Given this list of marker genes Cox11, Ifit3b, Mterf1a, Fam174a, Supt5, Dhdds, Csnk1g1, Washc4, Cyb5d1, Adsl, Nucb1, Srebf1, Zfp60, Zfp384 (NCBI Gene Id 269800), Prorp, Lsm10, Hspb6, Cplane2, Tbc1d10b, Snord13, Rny1, Nat10, B130034C11Rik, Pigu, Cdk5, Gm23596, Tnfaip1, Gm11527, Smpd3, Gtf2b, Uggt2, Neil1, Unk, Xpo6, Prkar1a, Wdr75, Mrpl48, Mrps10, Tor2a, Ddx23, Nbr1, Nrdc, Sp140l2, Dpagt1, 4833445I07Rik, Zfp148, Mphosph10, Atp6v0b, Sfi1, Slc30a5, Syt3, Tox4, Car11, Cyb561a3, Mrps9, mt-Tm, Uckl1os, Iscu, Samsn1, Ndc1, Prdm2, 1110038B12Rik, Zfyve19, Rgs12, Cep89 (NCBI Gene Id 72140), H2ac18, Farsb, Sympk, Setmar, H2-M3, Snrpd3, Gabpa, Ugt1a1, B2m, Hypk, Lamtor1, Ppp1r12c, Atpsckmt, Taf7, Commd9, Rab29, Med20, Zfp759, Pnrc2, Uqcr10, Yars1, Lcorl, Rad17, Atf6b (NCBI Gene Id 54136), Aptx, Mfap1b, Rexo2, Dhodh, Bub1b, Dhfr, Cep76, Trmt1, Wdfy1, Snord1c, Vipas39, Cyb561d2, Rpain, Alpi, Rad51, Snx17, Wdr83, Klhl28, Ubr2, Max, Espl1, Cactin (cactin, spliceosome C complex subunit), Prpf19, Cilk1, Mzf1, Hsp90b1, Dnase1l3, Zfp128, Aurka, Vcpip1, Sde2, Cep120, Eif3e, Atp5po, Insig2, Ppp1r13l, L3mbtl2, Rmrp (NCBI Gene Id 93782), Tdg, Gm17259, Fryl, Men1, Aimp1, Ccdc163 (NCBI Gene Id 71260), Rprd2, Ift81, Rgs18, Pask, Map4k1, Zc3h6, Ptprc, Mcur1, Fcmr (Fc fragment of IgM receptor), Gm6034, Mir3077, Alg2, Nsun2, Erg28, Cwc25, Tmem220 (transmembrane protein 220), Stradb, Sec23ip, Tap1, St13, Ccdc107, Nfatc3, Vmn2r115 (vomeronasal 2, receptor 115), Desi2 (desumoylating isopeptidase 2), Map3k10, Ndufs7, Gtf2h4, Fcsk, Wipf1, Eny2, Btg1, Eif2b4, Rps21, Aloxe3, S2bpcox16, Nars1, Fbxl9, Hirip3 (NCBI Gene Id 97405), Trappc6a, Gm26802, Faap24, Alg12, Hivep3 (NCBI Gene Id 73003), Trappc9, Klhl12, 1700003G18Rik, Snord42b, Sap18, Tufm, Trak2, Nampt, Gm10010, Sfswap, 9430065F17Rik, Coq4, Dnajc2, Ogdh, Tmem101, Psmc2, Osbpl11, Mitf, Mfap1a, Ddx47, Commd6, Polg, Entpd6, Lrpprc, Sap130, Ndufaf3, Cwc22, Rpgrip1l, Fbxo8, Sdccag8, Snapin, Zfp457, Brca1, 9930111J21Rik2, Rnu11, Cdk19, Rps12, Bfar, Larp4, Harbi1, Lamtor2, E330013P04Rik, mt-Nd5, Edem3, Wbp1l (WW domain binding protein 1 like), Chchd4, Med31, Gosr1, Ubxn4, 4933430I17Rik, Pex26, Uqcc4, Yif1b, Ccnl1, Pex12, H2bc18, Mks1, Ift70b, Morf4l1, Bet1, Mynn, Pphln1-ps1, Psmc4, Cldnd1, Nmi, Gm13293, Tmem94, 9430015G10Rik, Gclm, Epo, Upf2, Psmb8, Plaa, Tial1, Gm5113, Enkur, mt-Nd1, 4930513N10Rik, mt-Co2, Adck1, Agbl5 (NCBI Gene Id 231093), B3galt6, Mir3091, Cox7c, Zfp790, Sacm1l, Ephb6, Itfg2, Pemt (phosphatidylethanolamine N-methyltransferase), Csnk2b, Psmd1, Trappc2b, Wbp2 (WW domain binding protein 2), Tex9, Tpx2, N4bp2l2, Gm15247 (NCBI Gene Id 100379606), Nudt13, Smim30, Mir6359, Rbbp4, Nup88, 2210016L21Rik, BC005624, Chkb, Fam53c, Dnajc12, Eif4g1, Rab4b, Nt5c3, Cct5, Uspl1, Pex7, Pik3ca, Swt1, Tubd1 (tubulin, delta 1), Brk1, Rab5c, Edrf1, Rpl18, Zfp788 (NCBI Gene Id 67607), Ppp1r7, Exosc10, Rnf14, H4c16, Tacc3, Kat7, Mrpl44, Ndufv3, Mrpl32, Cenpx (NCBI Gene Id 20892), C2cd3, Lztr1, Wdr37, Gm7285, Mir1955, Cxxc1, Noa1, 1700037C18Rik, Tbl3, Wdr76, Vmn2r-ps18, Adss2, Atg13, Pbdc1, Vcf1, Pfdn6, Gucd1, Zbtb8os, Rabac1, Pnkd, Tmem267, Gm16023 (predicted gene 16023), Trim59, Madd, Ptbp1, Ttc1, Vps52, Nme7, Gm10044, Cic, Bloc1s3, Rexo4, Trim34a, Rad18, Slirp, Airim (NCBI Gene Id 194268), Pcm1, Gm6410, Pag1, Prmt5, Slmap, Serbp1, Wdr62, Umps, Thap11, Mmachc, Rps5, Wdr12, Zranb3, Rps6kb1, mt-Tv, Fbxo9, Zscan2, Taf13, Smarca4, Cdca8, Rfk, Fbxw7, Gspt1, Dph3, 1700022N22Rik, Usp48, Rsbn1, Krtap12-20, Bag6, Mutyh, Nfxl1, 4933431K14Rik, Etfdh, Rpl41, Ppp4r2, Cops2, Esf1, Sec11c (NCBI Gene Id 66286), Ccng2, Zfp830, Zfp110, Rrm1, Abhd13, Ahsa1, mt-Tn, Pafah2, Ndufv2, Ccdc174, H2-Q4, Nek11, Zfp747, Serinc4, Mrpl46, Trpm8, Tmx4, Nfkbie, Klhl9, Cftr, Tsnaxip1, Rab13, Pgam1 (NCBI Gene Id 68006), Cox15, Vti1b, mt-Ta, Slc35b4 (NCBI Gene Id 75817), Rab10os, Fbxl19, Mettl17, Smc2os, Hexim1, Trub2, Spice1, Dpp3, Cradd, Taco1, mt-Tl2, mt-Ty, Arpc5l, Srcap, Rnf114, Xpr1, Egln2, Sfxn4, Trim28, Lrrc45, Ppih, Acot2, H2ac19, Nosip, Hsbp1, Thrap3, Mad1l1, Calcoco1, Lsr, Rps18, Zfp84, Drg2, Gm40332, Emsy, Flad1 (flavin adenine dinucleotide synthetase 1), Mrps36, 3110070M22Rik, Banp, Ube2s, Apmap, Ift70a1, Ier3ip1, 2500004C02Rik, Rad52, Klhl20, Hs2st1, Sel1l, Pdzd7, Sfxn3, Dph6, Mfsd3, Capn15, Cfap96 (cilia and flagella associated protein 96), Ufm1, Cbr4, Knl1, Zfp146, Mir8098, Farsa, Ehd1, Rpl38, Rpl15, Rps27a, H2ac6, Ccser2, Xrra1, Zfp784, Naa38, Dnaaf10, Atg7, Nme1, Mterf2, Gbp10, Ddx18 (DEAD box helicase 18), Tmem43, Crebl2, Nfatc2ip (nuclear factor of activated T cells, cytoplasmic, calcineurin dependent 2 interacting protein), Chil5, Arap1, Otud5, Brpf1, H2-Q6, 6030442K20Rik, Sgf29, Calu, Zfp26, Rps8, Dcakd, Kbtbd8, D030040B21Rik, Rex2 (reduced expression 2), Pprc1, Gpank1, Psma2, Rab23, Hipk2, Rab2b, Mir9769, Mak16, Tmem39a, Anapc15, Wwp1, Gfap, Ube2i, Hmbox1, Invs, H4c3, Eif2s2, Mbd1, Sugp1, S100pbp, 1810024B03Rik, Cnih4, Atg9a, Galk2, Phb1, Prpf38b, 5530601H04Rik, Srebf2, Mettl26, mt-Tf, Camsap2, Ccdc77, Exoc7 (exocyst complex component 7), Pole3, Gm19684, Cryzl1, Pabpc4, Zmat5, Phf12 (NCBI Gene Id 76807, PHD finger protein 12), Pmm1, Tnip2, Srfbp1, Akt2, Tube1, mt-Th, Nufip2, Ftl1, Zfp58, Ccdc124, Vps4b, Mvb12a, Trim23, 2010110E17Rik, Hmgb1 (NCBI Gene Id 15289), Ddx49, Cnpy4 (canopy FGF signaling regulator 4), Fh1, Rpl34, Hdlbp, Slc4a2, Anapc7, Asxl1, 4833439L19Rik, Toe1, Rpl24, Tnfaip8l2, Slc39a3, Slc39a13, Rnu12, mt-Cytb, Fbxo48, Prmt6, Duxf3, Mlf2, Ak9, Rps27, Zcchc8, Jtb, Itpr1, Dmac1, Nek7, Uqcrfs1, Icam2, Zmym1, Ctdp1, Crebzf, Dot1l, Klhdc9, Bub3, Cep57l1, Ppme1, Mrpl34, Tmed1, Seh1l, Ndufs2, Smdt1, Snord60 (NCBI Gene Id 115488833), Cops4, Carf, Tdp2, Slc35a3, R3hdm1, Dcaf6, Wasf1, Fbxl15, Cnot10, Pdcl, Trub1, Rab27a, Mir707, Duxf1, Poldip3, Exosc5, Cwf19l2, Dctn6, Atp5pb, Supt7l, Dis3l2, mt-Tp, Nasp, Cope, mt-Nd4, Yme1l1, Cds2, Gm23130, Chrdl2, Adk, Ndufb5, Snhg16, Sla2, Gm13421 (predicted gene 13421), Paip2, Grk4, Btrc, Cdc40, Gm7945, Bcl2l12, Rbm5, Ifrd2, Mrpl19, Atl2 (atlastin GTPase 2), Gm20513, Ift46, Nxn, Zfp260, Dtl, Blzf1, Fastkd5, Dhx38, Galm, Gnb2, Get1, Cblb, Phospho2, Nop14, Fyco1, Psmb5, Atp6v1c1, Dnajc17, Spns1, Nop10, Mospd3, Kif2c, Alkbh8, BC051226 (cDNA sequence BC051226), Rad54b, Fig4, Dpm1, Dync1i2, Dcps, Abcf2, Zswim9 (NCBI Gene Id 321008), Vta1, H2-K2, Ubox5, Psmc5, Lsg1, BB014433, Erp44, Cinp, Chmp4b, Amd1, Srd5a1, Gm21149 (predicted gene, 21149), Exosc3 (exosome component 3), Bloc1s5, Ppp1r12b, Kbtbd8os, Grcc10, Gm9750 (predicted gene 9750), Selenof, Arih2, Xpnpep3, Ppp2r5b, Kmt5c, Fuca1, Igkv13-62-1, Zbtb40, Pacc1, Tm9sf1, Pex10, Dcaf1, Sipa1l3, Arid4b, Gm23143, Dnaja3, Vps41, Szrd1, Hepacam2, Sass6 (SAS-6 centriolar assembly protein), Fpgs, Trap1, Kifap3, Gm13163, Alg9, Taf6, Polg2, Brms1l, Isca2, Sf3a3, Dnm1l, Arnt, Tspan6, Per1, Cdk12, Ammecr1l, Usp37, Atp5pf, Sart3, Septin2, Itsn1, Ppp1cb, Krr1 (KRR1, small subunit (SSU) processome component, homolog (yeast)), H2-T23, H2-K1, Cog3, 4930539C22Rik, Dpm2, Ercc1, Oxnad1, H2-T22, Cdk5rap2, Nop16, Cstdc2, Synj2bp, A930006K02Rik, Gm20517, Gm11704, Ubqln4, Afg1l, Rbm15, Timm22, Gata3un, Ankzf1, Chfr, Zfp953, Slc33a1, Cops7b, Zpbp2, Lrwd1, Cdk11b, Ppm1d, Ube2g1, Sirt4, 1700034P13Rik (NCBI Gene Id 73331), Gtpbp2, Sdf4, Cops3, Srsf2, Tmem129 (transmembrane protein 129), Rpia, Polr3gl (polymerase (RNA) III (DNA directed) polypeptide G like), Gm8357, Matcap2, Ggps1, mt-Tq, Hmgxb4, Rab21, Aff1, Erh (ERH mRNA splicing and mitosis factor), Zfp219, Cfap61, mt-Tc, 2310039H08Rik, Lmbr1l, Ranbp10, Jmjd8, Rps7, Zmat2, Ftsj3, Hmgb3, Rab26os, Peak1, Washc1, Tmem41b, H2-Q7, Zfp383, Wdr36, Gid4, Unc45a, Rab3gap2, Atp5mc1, Utp11 (UTP11 small subunit processome component), Atp5mg, Tmem156, Stau1, Aak1, mt-Nd4l, Gm13158 (NCBI Gene Id 666557), Ppp6c, Mitd1, Ufsp2, Tysnd1, Rpp14, Tcf3, Trmt12, Lca5, Polr1g, Ushbp1, Med4, Timm21, Hmgcs1, Tfpt, Ap5s1, Tfcp2, Slc4a1ap, Zbtb17, Cdc123 (NCBI Gene Id 98828), Ostc, mt-Ts2, Rab8b, Akt1s1, Tomm40l, Usf1, Il1rl2, Ccpg1, Ap2b1, Snx16, Selplg, Foxo6, Edc3, Erlin2, Ulbp1, Kif15, mt-Rnr1, mt-Co1, Trappc13, Usp5, Traf7, Spag7, mt-Nd2, Slc39a7, Atp6v0a1, Utp3, Txndc11, Tsc22d4, Nek4, Ipo13, Gm17039, 1110002L01Rik, Zup1 (zinc finger containing ubiquitin peptidase 1), Pdcd10, Dgkz, Cluap1, Ralbp1, Rttn, Fbxo38, Or52z13 (olfactory receptor family 52 subfamily Z member 13), Ciao1, Gpbp1l1, Atp13a4, 1700007L15Rik, Gmpr2, Snhg12, Prcc, Polr3f, Htra2, Hbs1l, Ypel5, Cir1, Adipor2, Wdr81, Ap3m1, Lyrm9, Rfc3, Riox1, Scrn3, Rplp2, Zfp729a, Tmod3, Rpl36, Cenpl, Nr6a1, Surf6, Tyw3, Phf23, Elp3, Hsph1, 1600014C10Rik, Tdp1, Mtrf1l, Gbp3, Raver1, Ablim2, Tmem208, Ifit1bl1, Fis1, Tmem115, Rps25, Alkbh4, Aga, Dhx15, Cstf1, Dctn4, Catspere2, Slc22a29, Ints9, Bola1, Rpa2, Prrg2, Gm9758, Borcs7, Stil, Srp14, Sidt2, Wnk1, Kti12, Wrnip1, Mrps11, Slc41a1, Tomm5, Yars2, Aqr, Rps3a1, Nuf2, Fen1, Mm2pr, Trmt1l, Cmah, Fbxl17, Irgq, Zc3h3, Ceacam1, Alkbh1, Dubr, Smim7, Zfp444, Rnft2, Zscan22, Rlf, Apba3, Nicn1, Rnf20, Fastkd1, Dtx2, 9130604C24Rik, Cct6b, Cfap210, Pop7, Napepld, N4bp1, Taf15, Irf3, Gm25541, Brms1, Gtf2f1, B9d1os, Pigm, Rpl4, Mir7075, Psmd4, Zfp770, Foxa3, Eldr, Miga2, H2-T10, Traf5, Ubp1, Thnsl1, Fdps, Sf3b2, Hmg20a, Tssc4, Plekhg2, Rpl23a, Lig1, N6amt1, H2-Q5, Mrps5, Katnal1, Cdca3, Zcwpw1, Gm26205, Mau2, Zfp606, Uqcrh, Polr2b, Zfp566 (zinc finger protein 566), Fbxo46, Dmxl1, Glce, Ino80b, Slc39a9, Kif9 (kinesin family member 9), mt-Tl1, Aarsd1, Mrpl55, Pa2g4, Clptm1, Nthl1, Gipc2, Aste1, Odad3, Tbck, Zfp738 (zinc finger protein 738), Sphk2, Vcp, Slc38a10, Vps50, Spcs2, Czib, Gm11520, Gpkow, Calm3, Rpl19, Sesn1, Otud6b, Mrpl30, 6530401F13Rik, Rbbp5, Mff, 4930579G24Rik, Slx4ip, Fgd4, Ccdc126 (coiled-coil domain containing 126), Rpl26, Hdhd2, Micos13, Snd1, Sac3d1 (SAC3 domain containing 1), Hikeshi, Tbrg4, Sf3b4, Rpl6, Arhgef1, Mtnap1, mt-Tr, Plgrkt, Zfp607b, H4c9, Sbf1, Ndufs5, Snrnp200, Trip4, Spink10, Pank3, Pyroxd1, Dhx36, Top3a, Tmem167b, Higd2a, Zfp661, Cep170, Cant1, Tpgs1, Atp10d, Tspan3, Fam8a1 (NCBI Gene Id 97863), Polr2m, Lemd2, Taf1a, Mdm1, Wdr87-ps, Xndc1, Psmd3, Or10aa1, Aco1, Smim19, Fus, Sharpin (SHANK-associated RH domain interacting protein), Gm26352, Tmem138, Tmem64, Rnf10, Cks1b, Coa4, Abt1, Aup1, mt-Td, Pradc1, Fancc, Trmt10b, Rad54l2, Ado, Rsl1, Cnot4, Pmvk, Txnl4b, Neurl4, Hmgcr, Gm43391, Ranbp2 (NCBI Gene Id 353053), Gorab, Timm13, Marf1, Nup85, H2-Eb1, Lsm2, Bcl2a1d, Zfp787, Clp1 (NCBI Gene Id 98985), Ubxn2b, Tbc1d32, Patj, Esco2 (establishment of sister chromatid cohesion N-acetyltransferase 2), Katnbl1, Bysl, Ube2g2, 0610040B10Rik, Enthd1, Fam168a, Hjurp, Bud31, Tmem192, Vps8, Mindy1, Nfkbil1, Gin1, Napa, Dffa, Ap2s1, Lrrc41, Klhl18, Ndufv1, Eloc, Ttll5, Gm26330, Ssmem1, Tia1, Mtmr4, B9d1, 1110004F10Rik, Pomk, Hadha, Tmem243, Ccdc191, Sec62, Fkbpl, Wdr46, Pes1, Ormdl3, Ssr2, Nup153, Kifc1, Cdk10, Ints8 (integrator complex subunit 8), Vrk1, Efcab11, St3gal2, Ndufa9, Gm25744, Dhx33, Zfyve1, Kbtbd6, Gtf3a, Maf1, Eif3c, Calr3, Clhc1, Zfp748, Actr1b, Creld2, Dpp8, Tut1, Zmym6, Zfp235, Smc2, 4933404O12Rik, Smarcal1, H2bc4, Fbf1, Rps3, Itpkc, Nup205, Setd6, Usp31, Slc23a2, Trp53, Ap1ar, Vps45, Eaf1, 1810019N24Rik, Dars2, Spef1, Haus6, Dcaf11, Oxa1l, Crtc2, Brat1, Rpn1, Tmem191, Zbp1, Chrac1, Lrrfip2, Pdhx, Stk25, Cdadc1, Ahctf1, Sp4, Babam1, Cnot1, 1700128A07Rik, Mpc2, Lman2, Cep128, Snord55, Ubxn7 (NCBI Gene Id 381042), Ankra2, Spdye4b, 1700008O03Rik, Rnft1, Ak6, Rxrb, M6pr, 2810414N06Rik, Smcr8, Suclg1, Ppcdc, Smim13, Med25, Iqgap3, Rnf121, Trpc4ap, Sema3b, Daxx, Krt222, Kxd1, Suco, Ufd1, Tmem127, Tti2, Mrpl54, Rbm25, Dis3, Ccdc181, Ing3, Tbc1d17, Avpi1, Mis18a, Scp2, Terf2, Qtrt2, Scaf1, Rac3, Pnisr, Rangap1, Ddit3, Zfp87, Tarbp2 (TARBP2, RISC loading complex RNA binding subunit), Gpr19, Ift56, Fbxo28, Eftud2, Gm37885, Shc1, Dhx8, Pitpna, Ap4e1 (adaptor-related protein complex AP-4, epsilon 1), Pde6d, Smn1, Smarca5 (SWI/SNF related, matrix associated, actin dependent regulator of chromatin, subfamily a, member 5), Tcf4, Thg1l, Rabif, Nmbr, Zfp933, Yipf2, A730085K08Rik, Orc4, Gm26306, Trappc4, Ctu1, Fto, Eif3k, Wdfy2, Mib2, Ino80e, Taf9, mt-Ti, Grwd1, Ncln, Zfp691, Cfap20, Lclat1, Phlpp1, Aph1a, Clec16a, Rbl2, Sirt2, Atxn7l2, Dzank1, Smim11, Zfp940, Tssk6, Mfsd11, Ubr3, Poc1a, Ift20, Ccnl2, 2610005L07Rik, Wdr77, 1110019D14Rik, Katnb1, Caprin1, Blcap, Med24, Nudt5, Cep135, Rab11a, Mlst8, 1110002J07Rik, Mir1938, Xntrpc, Akirin2, Scamp2, Gbp8, Dus1l, Nelfb, Rabepk, Taok1, Tespa1, Dedd, Zfp414, Vps35l, Smok3c, Nrde2, Zfp273, Mcee, Snora7a, Med6 (mediator complex subunit 6), Rpl18a, Rab3a, Cct8, Snora16a, Rnf44, Tmed10, Cdc45, Naa40 (N(alpha)-acetyltransferase 40, NatD catalytic subunit), Pcp4, Zdhhc4, C87436, Enkd1, Nedd8, Arhgap11a, Nprl2, E230015B07Rik, Nutf2, Usf3, Elp6, Crnkl1, Pkn3, Rptor, Ppp1r37, Ap2m1, Mastl, Mrtfa, Togaram1, Cd48, Rpl27, Mepce, Iqcg (NCBI Gene Id 69707), 4933424G06Rik, Lrrc40, Faf2, Wrap53, mt-Rnr2, Trim12c, Stxbp4, Tmem258, 1700049E17Rik2 (tandem duplication of RIKEN cDNA 1700049E17 gene, gene 2), Cd84, Wapl, Angel2 (NCBI Gene Id 98446), Rps26, Snrpe, Mir7j, Rbak, Prpsap1, Csnk2a1, Gm37292, 4933405L10Rik (RIKEN cDNA 4933405L10 gene), Atp6v0c-ps2, Atpaf2, Zfp202, Zfp746, Ppp2r3c, Aamp, Fmc1, Abraxas1, Ppp4r3b, Kpna3, Amn1 (antagonist of mitotic exit network 1), Mir5133, Lars1, Pdap1, Med17, Mid1, Sec61b, Cox7a2l, Gm11201, Pde4dip, Calcrl, Aplf, Vps51, Cryz, Ppp1r21, Sil1, Nfkbib, Ghitm, Hspa9, Gtf3c5, Atg5, Wsb1 (WD repeat and SOCS box-containing 1), Pno1, Ccdc103, Bckdha, Kansl1, Chchd3, Pin1, 5830454E08Rik, Rdh14, Chd8, Psmb9 (NCBI Gene Id 16912), Decr2, Tmem161a, Ints3, Fam229b, Cep44, Hdgf, Apbb1ip, mt-Tw, Bod1, Rpl11, Kdm8, Mkks (McKusick-Kaufman syndrome), Zfp85 (NCBI Gene Id 386624), Ndufa3, Hadhb, Ifrd1, Nkiras1, Rnu7, Nmt1, Pals1, Coil, Rpl35a, Polr3b, Atp6v1g2, Mettl6, Rps23, Snrnp70, Dhx16, Tsc2, Ahcyl2, Kbtbd7, Ing4, Ddost, Speer4cos, Wtip, Prpf31, 1700030K09Rik, Cep78, Wdr73 (WD repeat domain 73), Cnot9, Gmfg, Mir1945, Rpl32, Sipa1, Serpini1, Gtse1, Rps14, 2810408A11Rik, Spata31e2, Zfp157, Prune1, Gsk3a, Prkcsh, Nlk, Atad2, Tgif1, H3c7, Pierce2, Zfp458, Poc5, Nvl, Tfeb, Lig4, Chordc1, Zwilch, here is a description of the gene set: species: Mus musculus Mouse Gene Set: NLRC5_TARGET_GENES from publication Yevshin I, Sharipov R, Kolmykov S, Kondrakhin Y, Kolpakov F (PMID 30445619)